The following is a description of a gene set: Human Gene Set: GOMF_IGG_BINDING species: Homo sapiens Binding to an immunoglobulin of an IgG isotype., and this is the list of marker genes: FCGR2A, FCGR3B, FCGR2B, PIP (NCBI Gene Id 5304), UMOD, FCGR1BP, FCGR3A, FCGR1A, FCGRT (NCBI Gene Id 2217), FCER1G, FCGR2C